The following is a description of a gene set: The appearance of a cell adhesion molecule due to biosynthesis or secretion. species: Homo sapiens Human Gene Set: GOBP_CELL_ADHESION_MOLECULE_PRODUCTION, and this is the list of marker genes: MYOCD, GOLPH3, CXCL8, MIR206, MIR221, FUT7, CAV1, IL1B, PPIA, MIR144, MIR1298, MIR20A, MIR101-1, MIR520C, MIR374A, MIR27B, NOTCH1, NOTCH4, MIR222, APOA1, GCNT1, MIR506, MIR146A